The following is a description of a gene set: studied in species Mus musculus Mouse Gene Set: GOMF_GALACTOSE_TRANSMEMBRANE_TRANSPORTER_ACTIVITY Enables the transfer of galactose from one side of a membrane to the other. D-galactose is widely distributed in combined form in plants, animals and microorganisms as a constituent of oligo- and polysaccharides; it also occurs in galactolipids and as its glucoside in lactose and melibiose., and this is the list of marker genes: Slc2a3, Slc45a1, Slc2a8, Slc2a2, Slc5a1 (solute carrier family 5 (sodium/glucose cotransporter), member 1)